The following is a description of a gene set: studied in species Homo sapiens Any process that stops, prevents or reduces the frequency, rate or extent of matrix metallopeptidase secretion. Human Gene Set: GOBP_NEGATIVE_REGULATION_OF_MATRIX_METALLOPEPTIDASE_SECRETION, and this is the list of marker genes: MIR199A1, MIR146A, MIR29B1, MIR19A, CD200, IDH2, MIR19B1, MIR766